The following is a description of a gene set: MET promotes cell motility Mouse Gene Set: REACTOME_MET_PROMOTES_CELL_MOTILITY studied in species Mus musculus, and this is the list of marker genes: Crkl, Col11a1, Tns3, Col5a3, Src, Rac1, Col1a1, Itga2, Grb2, Tns4, Rapgef1, Col3a1, Hgf, Lama4, Rap1a, Itgb1, Crk, Rap1b, Col1a2, Col2a1, Col11a2, Fn1, Dock7, Col5a1, Megf6, Met, Ptk2, Itga3, Col5a2, Gab1